The following is a description of a gene set: from publication Chauhan D, Li G, Auclair D, Hideshima T, Richardson P, Podar K, Mitsiades N, Mitsiades C, Li C, Kim RS, Munshi N, Chen LB, Wong W, Anderson KC (PMID 12480690) Our previous study demonstrated that 2-methoxyestradiol (2ME2), an estrogen derivative, induces apoptosis in multiple myeloma (MM) cells; however, the related transcriptional events are unclear. In the present study, we used oligonucleotide microarrays to identify genes altered during 2ME2-induced apoptosis in MM cells. 2ME2 triggers an early transient induction of genes known to trigger cell death and repression of growth/survival-related genes. Many genes regulating cell defense/repair machinery also were transiently induced. Since 2ME2 also induces apoptosis in MM cells resistant to conventional therapies such as dexamethasone (Dex), we compared the gene profiles of 2ME2-treated and Dex-resistant MM cells. Our results suggest that 2ME2 overcomes Dex resistance by modulating genes that confer chemoresistance in MM cells. Microarray results were confirmed by Northern and Western blot analyses. A comparative analysis of selected genes from freshly isolated MM patient cells and 2ME2-treated MM.1S MM cells further provides an in vivo relevance of our in vitro studies. Collectively, these findings suggest genetic events mediating anti-MM activity of 2ME2, as well as mechanisms whereby 2ME2 overcomes Dex resistance in MM cells. These studies may therefore allow improved therapeutic use of 2ME2, based upon targeting genes that regulate MM cell growth and survival. Genes down-regulated by 2-methoxyestradiol (2ME2) in the MM.1S cell line (multiple myeloma) sensitive to dexamethasone. studied in species Homo sapiens Human Gene Set: CHAUHAN_RESPONSE_TO_METHOXYESTRADIOL_DN, and this is the list of marker genes: CD164, NCSTN, H4C3, RASA4, NAP1L1, LSP1, BTG2, TMSB10, TMT1A, COX6A1, ARPC5, NRDC, GNAS, EIF3F, TRBC2, MXI1 (MAX interactor 1, dimerization protein), ZFP36L2, ADM, ATP5MF, SLC25A6 (solute carrier family 25 member 6), ARL6IP1, DDX17, MAN2A1 (mannosidase alpha class 2A member 1), PABPC1, FDPS, H2AZ1, EIF3M, CD74, SEC61G, RPL12, CCL3, ATP6V1F, UBE2I, UGT2B15, NUCB1, CTBP1, BTF3, DDOST, SLC1A4, HLA-G, CYFIP2, PGK1, BTG1, UBC, ENSG00000291006, NME4, CSNK1E, IL2RG, MKI67, HERPUD1, H3P37, MARCKS, PIM2, VAMP2, LITAF, XBP1, HSP90B1, ENO2, EEF1A1, PTPN6, LGALS1, IDH2, LTA4H, UBA1, GGT1, CD48, ARHGDIB, MDH1, TMSB4X, TPP1, PCP4, PDLIM1, PHB2, TLN1, HCLS1, B2M (NCBI Gene Id 567), S100A10, ATP5PO, UBE2J1, AP3S1, HSP90AB1, MORF4L2, HADH, TUBB2A, CAPNS1, TAPBP, MCL1, FOXO3, EIF3K, ERP29, COPE, VIM, UBE2S, PKM, PCBP2, RAF1, TUBBP1, NPC2, AP1S2, TNFAIP3, EIF4B, ADD1, WBP2, SPCS2, CTDNEP1, YWHAB